The following is a description of a gene set: studied in species Mus musculus Mouse Gene Set: GOBP_T_HELPER_1_CELL_LINEAGE_COMMITMENT The process in which a CD4-positive, alpha-beta T cell becomes committed to becoming a T-helper 1 cell, a CD4-positive, alpha-beta T cell specialized to promote immunological processes often associated with resistance to intracellular bacteria, fungi, and protozoa, and pathological conditions such as arthritis., and this is the list of marker genes: Tbx21, Mtor (NCBI Gene Id 80612), Spn, Stat6, Il4